The following is a description of a gene set: Any process that activates or increases the frequency, rate or extent of DNA-templated DNA replication. species: Mus musculus Mouse Gene Set: GOBP_POSITIVE_REGULATION_OF_DNA_TEMPLATED_DNA_REPLICATION, and this is the list of marker genes: Cdk2, Wiz, Ager, E2f7, Atrx, Endog, E2f8, Cdt1, Mtnap1, Ciz1, Dbf4, Ino80, Ssbp1, Fgfr1, Cdc7